The following is a description of a gene set: electronically inferred by orthology from the curated human pathway This event has been computationally inferred from an event that has been demonstrated in another species.<p>The inference is based on the homology mapping from PANTHER. Briefly, reactions for which all involved PhysicalEntities (in input, output and catalyst) have a mapped orthologue/paralogue (for complexes at least 75% of components must have a mapping) are inferred to the other species. part of: Activation of the mRNA upon binding of the cap-binding complex and eIFs, and subsequent binding to 43S species: Mus musculus Reactome Pathway: Translation initiation complex formation, and this is the list of marker genes: Rps10, Rps18 (NCBI Gene Id 20084), Rps13, Rps11, Rps24, Rps8, Eif3g, Eif1ax, Rps4x, Eif4a1, Eif3i, Eif2s3x, Rps9, Rps3a1, Eif3e, Rps17, Eif3f, Rps26, Eif3j2, Rps12, Rps15, Rps19, Eif4a2, Rps23, Rps6, Rps7 (NCBI Gene Id 20115), Pabpc1, Eif3k, Eif3b, Rps27l, Rps28, Rps25, Rps5, Rps2, Fau, Eif3d, Rps20